Given this list of marker genes TBX4, HMGXB4, NUP210L, OXGR1, SERTAD2, DCDC1, INTS6, SPRY4, ZBTB2, KPNA3, ITPRIP, NXPH2, CLUL1, TRIM27, SLC44A1, RRAGA, BNC2, TNRC6B, LIPA, DMD, KCNIP4, STRN3, PMP22, PPP2CB, TP53AIP1, IDI2 (isopentenyl-diphosphate delta isomerase 2), FBXO25, CALCB, KDELR2, NEXMIF, VPS54, IKZF1 (IKAROS family zinc finger 1), KANSL1L, KCNQ3, VSNL1, KLKB1, INO80, KDM3A, IFNAR2, TNPO2, HNRNPC, CCNK, TMPPE, HIP1R, TMSB15A, MTHFD2L, KLHL9, BTAF1, YTHDF3, VCPIP1 (NCBI Gene Id 80124), FBXO22, MRPL43, LRRC8B, JMY (junction mediating and regulatory protein, p53 cofactor), MAP3K13, NPHS1, SMARCAD1, PDCL, SNX14, C2CD4A, GOPC, EGLN3, DPH6, ZNF264, EIF2A, LURAP1L, STMN4, PLPP6, PRKG1 (protein kinase cGMP-dependent 1), RNF216, BCL11B, ENTHD1, ELAVL2, SRPK1, TTC9, ST6GALNAC5, UQCRB, HSPA1L, JARID2, UBP1, MBL2, ZNHIT6, STAC, here is a description of the gene set: Genes predicted to be targets of miRBase v22 microRNA hsa-miR-10524-5p in miRDB v6.0 with MirTarget v4 prediction scores > 80 (high confidence targets). studied in species Homo sapiens from publication Chen Y, Wang X (PMID 31504780) Human Gene Set: MIR10524_5P